The following is a description of a gene set: Any process that results in a change in state or activity of a cell or an organism (in terms of movement, secretion, enzyme production, gene expression, etc.) as a result of an interleukin-12 stimulus. Mouse Gene Set: GOBP_RESPONSE_TO_INTERLEUKIN_12 species: Mus musculus, and this is the list of marker genes: Il12rb2, Tyk2, Ripk2, Cd47, Il12b, Sirpa, Jak2, Il12a, Ticam2, Stat4, Il12rb1, Gm36723, Plcb1